Given this list of marker genes Sash1, Rit2, Lrrc39, Rnf111, Pramel51, Oog1, Psd3, Pramel24, Pou2af2, Nars2, Crp, Cyp2b23, Tcp10a, Rabgap1l, Zfp248, C8a, Hs3st5, Klhl28, Mdk, Foxred2, Tsc1, Yme1l1, Sphkap, Stag1, Car6, Slc12a8, E2f8, Ica1l (NCBI Gene Id 70375), Sult6b2, Aass, Akt3, Uba1, Gm2042, Cldn16, Gpr157, Actbl2, Brox, Ndufaf4, Fli1, Slc4a7, Fbxw7, Pramel29, Pramel25, Tcp10c, Zfp74, Tpcn2, Gm5878, Oog3, Zfhx4, Zfp459, Csf2ra, Tfdp1, Gpr37, Krtap19-9b (NCBI Gene Id 170939), Rad50, Tpmt, Bhlhe22, Robo1, here is a description of the gene set: species: Mus musculus Genes predicted to be targets of miRBase v22 microRNA mmu_miR_509_3p in miRDB v6.0 with MirTarget v4 prediction scores > 80 (high confidence targets). from publication Chen Y, Wang X (PMID 31504780) Mouse Gene Set: MIR_509_3P